Given this list of marker genes ZMYM4, FAM76B, TFRC, ZFY, NGDN, WWC2, CENPE, TCERG1L, BAZ1B, CRACD, SGO1, YY1, CPNE2, RPS16, CLDN16, PEAK1, CEP192, SLC18A2, FGF7, WAC, KDM6A, KIN, YTHDC1, SEMA3C, ID4, SLC4A5, AGTR1, COG7, POU2AF3, PHIP, LRP1B, ULK1, CLASP2, EIF4ENIF1, SP4, TRIM63, FBXO34 (NCBI Gene Id 55030), NUDT12, F3, JPH1, ZMIZ1, MALT1, IGF1R, DLX2, LIN9, PRR12, E2F5, MEF2D, KBTBD7, DCC, TCF20, MRPL44, VCL, DNALI1, AFF3, DLL1 (delta like canonical Notch ligand 1), L3HYPDH, NECTIN1, BCAP29 (NCBI Gene Id 55973), TAFA4, GIGYF2, PCDH8, PRPF38B, ZNF292, PLEKHA6, UTRN, OTX2, SH3GL3, OLFML2B, KLF3, CCDC102B, OLIG3 (NCBI Gene Id 167826), GNA13, POLR1F, NBEA, GOLGA2, LTN1, LGALSL, TMTC4, ARHGAP44, ARFGEF2, SMARCA2, IMPACT (NCBI Gene Id 55364), SLC34A2, PPFIA2, ROCK1, RNF180, DCAF7, CEP57, LRRC4, TSLP, PRPF8, ARID4A (NCBI Gene Id 5926), NPY1R, ITCH (itchy E3 ubiquitin protein ligase), PDLIM5, CDK19, ALG10B, SUN1, ICE1, APOOL, ASAH1, PALS2, PTER, FGD6, CCNY (NCBI Gene Id 219771), MTARC1, RNF149, CPEB3, XPO1, PHACTR2, RSF1, MED14, PPM1A, GRK5, MMAB, KCNJ15, HYCC2, RIF1, RABGGTB, PPP1R15B, SCAMP1, BRD1, TASP1, MMS22L, SEPHS1, NF1, ITM2C, NR3C1, WASF3, TMEM87A, SGTB, UBE2H, DMTF1, U2SURP, DR1, FBXO43, HNRNPA2B1, ZNF506, SYF2, ZFPM2, FAM204A, TTF2, NLGN1, ZFYVE21, MAST4, COL11A1, ZBTB39, HMGXB4, CRY1, LIX1L, CUL1, ELOVL2, VEZF1, EPS15L1, NADK2, TNS3 (tensin 3), RTN1, ALDH1L2, MTF1, GRM5, DACH1, NPY, PPP1R2, UBL3, PSD3, TRAK1, GLCCI1, SLC2A13, OXR1, ZNF569, DCLK3, IRX3, MECOM, GULP1, LY75, GLS, GSK3B, CHD3, HSPA14, AKTIP, POLR2K, PFKFB3, SPRY1, CAMTA1, BMP3, RAB10, MAGI1, PTBP3, TMEM132B, PUM1, ZNF367, SALL3, SRSF1, ZNF236, RHOT1, KRAS, SNAPC1, FBXL3 (F-box and leucine rich repeat protein 3), ADAM28, DENND1B, ZNF827, ANO4, PSD2 (NCBI Gene Id 84249), CCL7, CAB39, TET2, PLPP3, PTPRE, ELK4, RBPJ, RHOBTB3, UBXN7, SPAST, EEA1, BMPER, ELAVL2, DOCK1 (dedicator of cytokinesis 1), FOXP1, UBTF (upstream binding transcription factor, NCBI Gene Id 7343), CEP76, PUM2, RICTOR, FLT3LG, PLAG1, NUFIP2, PRDM16, APP, TAF2, MED6, SPINDOC, TVP23B, SDHAF3, E2F8, SCN7A, SRBD1, GUCY1B1, LYPLAL1, BTBD3, DSG2, EMP2, SELENOK, NRBF2, RALGDS (ral guanine nucleotide dissociation stimulator), GTF2A1, BTF3L4, RAB2A, APPL1, PNISR, ARHGAP20, PRRC1, SPOPL, EIF4A2, MINDY3, LSM14A, SMARCA5, ATP6V1H, MAPKAPK5, KLF2, ITM2B, CACNA2D1, SOS2, SCAI (NCBI Gene Id 286205), TRA2A, EDIL3, KLF4, SPOCK3, F2RL1, BST1, NR4A3, TET3, SV2B, AKAP10, ANAPC13, PEX5L, BRF2, SOWAHC, SORBS1, BTNL9, DOCK11, AAK1, KIF2A, FZD6 (frizzled class receptor 6), NCKAP1, NR5A2, ERF, ANKRD44, IFT70A, C11orf54, PPM1D, CNR1, COL1A2, KLHDC2, SLC39A6, JAG2, MNX1, SDC2, HIVEP2, FBLN5, SNCAIP, SRSF11 (NCBI Gene Id 9295), ACTR3, RELCH, HES1, SCN2A, TEAD1, CCDC126, ACTL6A, GATA3, KIAA0408, TCF3, SRSF2, PARD6B, SBF2, UBR1, ITGA6, DCUN1D4, TAOK1, LIN54, CEP41, AKAP6, CASP8AP2, SCARF1, N4BP2, TVP23C (NCBI Gene Id 93602), CREBZF, RAB14, CLDN1, SET (SET nuclear proto-oncogene), CTTNBP2NL, SLAIN2, GNAI3, SLC6A14, GNAL, LYSMD3, FAM117B, RASEF, AP1S3, HNRNPD, RNF216, NDC1, DCBLD2, SPEN, EFNB1, PAN3 (poly(A) specific ribonuclease subunit PAN3), AKAP12, FOXN2, THAP12, SLC6A4, KPNA3, DOP1A, C18orf63, C7orf57, RAB11B, ADRB2, RBM12B, PRDM2, ZNF430, HECTD2, KIAA1217, MAN1A1, STK40, MBLAC2, TSHZ3, JAK2, BHLHE40, DGKH, MAP2, HIPK3, SECISBP2L, UBN1, PSIP1, MEX3B, WIPI1, CECR2, JAG1, OPA1, MAP2K3 (NCBI Gene Id 92079), NFAT5, GDAP1 (ganglioside induced differentiation associated protein 1), AKAP13, ARHGAP12, PPP1R21, FUT9, SLC35A3, LRRC1, RORA, ACTR3C, NTN4, ARHGEF33, ASB11, GDAP2, VMA21, DPM1, PI15, TRPM7, RFX1, AUTS2, RIMKLB, SP8, DERL1, PANK3, GNAQ, CWC22, MYCBP2, DENND4A, ZNF780A, ZNF326, KRBOX4, ERI1, BMPR2, KDM7A, IGFBP1, C11orf58, ELOVL7, ACBD3, SAMD12, ULBP1, FA2H, PRKAA1, ITGAV, FOXO1, KDM2B, UNC119B, SEPTIN9, C1QTNF7, CCNA2, CNTN1, HOXA9, BLTP1, HMGCR, ASAP2, RAPH1, COL4A1, SATB1, SPRY2, SLC6A17, CPEB2, EGFL6, NUDT4, WNT5B, PHC3, AMMECR1, TMED7, SLC6A11, NRP1, CD38, DCLRE1B, EPHB4, NUDT11, SYNGR3, FBXO45, FBXO33, DLL4, DAAM1, CCDC186, SPTB, ZNF302, FBN1, RBM22, TUT4, MON2, RPRD1B, CLDN12, VAV3, ATAD5 (NCBI Gene Id 79915), LAMP2, COL19A1, NUP35, HIC1, MSANTD2, RIPPLY2, EIF4G3, CEPT1, GRHL3, RPRD1A, GOLIM4, SOX9, RAB6D, BDNF, LATS1, EFR3A, DNAJB5, PDZRN3, SLC39A10, ATG2B, SFPQ, AHR, PCSK2, MBNL1, NOL4, CDH20, ZMYND8, RDX, UBE2Q2, LRRTM4, HIP1, DUSP6, ARHGEF28, NCOA2, UBE2W, TOB1, UBQLN1, ARID4B, PAK2, RC3H1, TLE4 (NCBI Gene Id 7091), CNNM4, NAA25, B3GLCT, FREM2, PPP4R2, NFYB, UBE3C, USP24, CNOT6, CTU2, THRB, PDE10A, HYCC1, PHYHIPL, HS6ST2, FAM3C, CIAO2A (NCBI Gene Id 84191), PIAS1, MMP20, ZNF518A, KLHL2, FNDC3A, USP34, RAB6B, MEF2C, MLLT6, ABI1, ARID1B, PTCH1, CEMIP2, SEC22C, CTR9, RAD21, FYTTD1, HOOK3, LRP6, NR2F2, CCNE2, RAB3GAP2 (RAB3 GTPase activating non-catalytic protein subunit 2), BLOC1S4, TRHDE, GRM3 (NCBI Gene Id 2913), CLIP1, BMAL1, RAB11FIP3, ZMYM6, GNB4, GPRIN3, HNRNPA1, LHFPL3, OTUD6B, CMPK1, ZC3H11A, MYCN, USF3, PTMS, SPESP1, FNDC3B, ALKBH8, ACVR2B, PARPBP, CALN1 (NCBI Gene Id 83698), PPP1R3F, UBN2 (NCBI Gene Id 254048), BTAF1, NEUROG2, IPMK, CACNA1C, MLLT10, HEATR5B, FRMD4B, CTNNB1, UBE2B, TAS2R14, ID1, FRS2 (NCBI Gene Id 10818), IKZF2 (NCBI Gene Id 51173), CERT1, PPP4R3B, C5orf58, EBF3, UBFD1, NAA16, NASP, KLF12, B3GNT2, DENND2B, CHD1, ZNF800, REV3L, STK24, LCOR (NCBI Gene Id 93376), TLE1, TIGD7, USP25, TRIM6, TAF4B, CILK1, BAG2, ATRX, POU4F2, HTR2A (5-hydroxytryptamine receptor 2A), PECR, ACVR1, FRMD6, CREBRF, LIPG (NCBI Gene Id 9388), NAA20, CRISPLD1, GPR158, GTF3C3, BRWD3, STK38L, RASGEF1A, RAB11FIP2, AKAP9, STON2, LRCH4, ATF2, GPR37, GABRG1 (NCBI Gene Id 2565), USP32, FSHB, NRP2, ANO5, GRIA3, TBC1D2B, EIF1AD, MATN2, TRGC1, MARCHF6, GTF2I, IREB2, ZBTB14, CORO1C, MPC2, ATL1, FGFR2, PPM1L, LRRC32, ARAP2, ZIC1, GP1BA, FAT3, DKK3, TGFB3, C1QBP, CARF, PPP3CA, KMT2C, ANK3, OTUD4, MARK1, ISM1, AASDH, KIF21A, HECTD1, ZDHHC20, RHOA, SHOC2, KIF3A, DACT1, MBNL2, CLOCK, KDM5B, DYNC2LI1, TGFBR3, INO80D, PIK3R4, ZNF518B, LGR4, RSRP1, FSTL5, FSCN1, WWC1, WDR26, NUP58, BRIP1, RNF24, VAPA, DNPEP, PAXBP1, BASP1, PIKFYVE (phosphoinositide kinase, FYVE-type zinc finger containing), MIF4GD, HERC2, BCL6, FNBP4, PIK3C2A, KIF11, RNF138, ARIH1, MYT1L, CNOT6L, PLCL2, SCX, CFTR (NCBI Gene Id 1080), CDC7, LILRA1, HNRNPA1L2, DOCK10, DDX21, SPRED1, DCAF6, IER5, CADM1, ETS2, TBR1, LEMD3, USP12, NUP98, TMTC2, CYP7B1, YTHDF3, TM4SF4, QKI, ZFYVE16, NKTR, here is a description of the gene set: studied in species Homo sapiens from publication Chen Y, Wang X (PMID 31504780) Human Gene Set: MIR98_3P Genes predicted to be targets of miRBase v22 microRNA hsa-miR-98-3p in miRDB v6.0 with MirTarget v4 prediction scores > 80 (high confidence targets).